Given this list of marker genes FGF23, HOXC10, HYAL2, FAM210B, CALM1, RUFY4, MECR, JPH2, STXBP4, LGALS9, INAVA, LIMA1, PRCP, CDH3, TMEM97, PNLIPRP3, ADA, ATP6V0B, MALRD1, ATP6V1G1, STAT1, SREBF2, UPK3A, ARHGEF5, AHSP, MTHFD1, FGF21, STEAP4, G6PC1, RAB11B, ACOT11, SLC12A9, CARTPT, SLC26A3, PDK2, EFNA5, CLCN6, MTLN, CCL14, CCR4, SLC22A12, MIR146A, GPRASP2, MIR15A, CCN2, SH2B2, TSHR (thyroid stimulating hormone receptor), ATP2B3, NUS1, OBP2A, TSPOAP1, CXADR, IMMT, ZNHIT1 (NCBI Gene Id 10467), VSTM4, P4HTM, BOLA2, TRPC6, PIANP, NNT, SNX10, CALCA, FOXK2, EIF4G1, STAT6, DOCK11, SLC26A4, SLC12A1, ASXL1, WHRN, CA7, SLC30A5, TTC39B, SLC26A6, RHD, MICU2, GP1BA, TSC22D4, GRAMD1B, BACE2, BCR, CXCL12, BGLAP, PLAC8, PPARGC1B, MT2A, PRDX6, SLC2A4, CCDC51, STIM2, SHANK3, ATP1B3, GP1BB, CRTC3, BCL2L11, INSR, PDE4D, CLDN12, TMPRSS6, SLC4A8, MIR204, PPP3CB, VPS54, RBM4, KCNA5, LCK, RHO, ADAM17, MT1B, CCN4, PSEN2, GNAS, RDH12, WDR48, AMBRA1, USF1, MUC6, TMCO1, IL7R, FTH1P19, COMT, SORL1, TGFB2, ATP5IF1, RACGAP1, MYO5B, NQO1, MYB, PNPLA4, PRKAB2, SLC39A10, KCTD17, PASK, CDH5, CSK, CXCR3, KIT, APOC2, SLC4A10, CRY1, MIR144, RMDN3, TRPM8, CCN3, GPR68, MB, AQP3, CRTC1, HMGB1, RHEB, CD74, FGFR4, AKT1, GNAT2, OXTR, TMEM94, ABCB4, PLCL2, MTNR1B, CD38, GRB10, DIO2, FUNDC2, AGER, FTMT (NCBI Gene Id 94033), PNLIPRP2, E2F4, CHD7, ESRRB, FGFR1, CCDC66, PRKAB1 (NCBI Gene Id 5564), ETNPPL, GAA (NCBI Gene Id 2548), CSF1, NPPC, ACACB, GATA1, CEMIP, ATP4A (ATPase H+/K+ transporting subunit alpha), GAPT, OAS1, KDM1A, RAB7A, TMEM64, CYP4F12, FOXN1, TNFRSF11A, SRF, MCOLN1, MIR185, BBIP1, TRPA1, SRI, ADAMTS5, NAPEPLD, CRH, ERCC2, STC2, RPTOR, TXNRD1, PDZD8, LAMA2, CCL5, FAM20A (FAM20A golgi associated secretory pathway pseudokinase), TMEM199, CCKBR, ATP2B2, BTK, GLRX3, GSR, CLCC1, SLC24A3, IL18R1, RMI1, PRKCE, AVPR1A, LAMTOR1, HAS2, NPR1, SMARCB1, GCM2, SLC12A8, SELENOT, LARGE2, ZNF251, NDP, TRPC3, CIB3, IKZF1, DISP3, BAIAP3, NGFR, CXCL9, SLC9A6, IGF1R, CMKLR2, SCNN1B, NMU, PRDX5, SIRT6, MPL, PLG, SPNS2, PLCB3, EPB42, MIR19B1, ANK3, SLC39A5, ADIPOR1, GSTM2, MPC2 (mitochondrial pyruvate carrier 2), ATP7A, GOT1, TNFSF13B, TXN, CMKLR1, BAP1, FKBP1A (FKBP prolyl isomerase 1A), PBLD, TWIST1, NPHP4, OSBPL11, INPP5K, UBE3A, SLC2A1, KCTD7, ATP13A4, NOVA2, HNRNPU, SLC30A9, PKN1, FXYD2, ATP13A3, PPT1, EDN1 (NCBI Gene Id 1906), PTCH1, AMPD2, ALMS1 (ALMS1 centrosome and basal body associated protein), GADD45G, NKX6-1, TMEM175, NDFIP1, CLIC2, RORA, LTBP3, SCN7A, SCO1, SEC24A, ZBED6, MED1, KLHL10, LACC1, HTR2A, ATP7B, BAK1, GDF3 (NCBI Gene Id 9573), SLC12A7, SLC45A2, PARK7, G6PC2, KRIT1, ALK, SPTA1, SLAMF8, ADISSP, CCDC47, CDH23, ISG15, PRDX2, MYC, OCLN, RAG2, CFTR, AKT3, ELP6, SLC1A1, ITPR1, ARAP1, TAL1, KCNA1, MIR320D1, EHMT1, QKI, NCAPG2, PTGS2, ACIN1, FECH, ABCB10, PROM1, NFIB, JMJD6, SLC29A1, ACSL1, SLC11A2, RNASEK, WNK1, WFS1, SLC4A3, COMMD9, DIAPH3, MT4, GATA4, GRIK2, ABCC8, TMC6, UBASH3B, IRS1, DLL1, CIAO3, AXL, SESN2, HTR4, MIR210, DMD, LDLRAP1, TPP2, NPTX1, PML, CRY2, SLC25A44, P2RX7, ACVR2A, SLC48A1, HTT, PHPT1, GCLC, ROGDI, TRPV1, CREG1, PLCE1, AGT, RP1L1, EPG5, TLCD2, SLC16A1, CNNM3, INHBA, F11R, HSP90B1, CHERP, MAPK8, SPNS1, MIR34A, BHLHA15 (basic helix-loop-helix family member a15), NELL2, CAV2, SH2B3, SSTR5 (NCBI Gene Id 6755), MUC4, CROCC, TMEM9, HCRTR1, NR5A2, CALB2, SLC24A5, USF2, ERRFI1, GPER1 (NCBI Gene Id 2852), GRM5, MIR128-1, ABCD1, DRAM2, MT1M, MFHAS1, PTPRN, TRPC5, MIR222, TRAF3IP2, TMEM14C, CALR, RAB30, FMO4, DCTN1, TMEM174, CCL7, SMAD5, PCK2 (phosphoenolpyruvate carboxykinase 2, mitochondrial), AFP, IL7, NT5E, NFE2L1, POC1B, LAMC1, MAK, YWHAE, TENT4B, SLC39A14, CASQ2, CCL11, HADH, CACNB2, PER2, MEF2C, RAP1GDS1, VGF, EGR1, IREB2, HECTD4, HCAR2, PPP2CA, CYB561A3, MERTK, PCSK1N, ATP6V1B1, WNK3, ABCG5, ACSM1, MAP2K1, COL2A1, GPR89B, SOD1, TRAF6, CYP39A1, ACADL, BBS1, KCNQ1, LRRC8E, ATP6V1A, CDH2, ZBTB20, SFTPD, CALB1, ENY2, HDAC3 (histone deacetylase 3), PDPK1, CCDC22, C19orf12, PRKCA, AQP6, SLC9A7, ANGPTL8, TRIM58, ATP6V0D1, SIDT2, HOXA5, AQP4, JAM2, FRRS1, PTH2R, UNC80, RAC1, SLC12A4, AVP, KAT7, PCTP, EPHX2, GRM2, ADCYAP1, ABCB8, RAB38, ITGB6, ADCY8, CX3CL1, ITPR3 (NCBI Gene Id 3710), KCNH2, RPE65, NF1, DRD4, CLDN18, CLN8, UBB, TRIM32, P2RX4, CCR1, ETV2, ATP1A1, COMMD1, RPS17 (NCBI Gene Id 6218), PNPLA1, EGLN2, ATP6V0D2, ATG5, PLA2G10, LIN28A, RHCG, MC4R, EDN2, ATP6V0E2, PGAM5, TRPC4, HAMP, COX19, TNFAIP3, SGCZ, ERFE, STAT3, S100A14, CADPS2, SLC39A6, SPPL2C, CUBN, XKR8, RBP1, HOXA13, MIR337, APLNR, SLC8B1, ABCB1, ATP1B1, OSBP, SLC30A10, SFRP4, SOX9, HSCB, NPC1 (NPC intracellular cholesterol transporter 1), ARMCX1, SLC4A1, GJB6, ALAS1, CRTC2, ELOVL6, SPI1, LDLR, APOM, ARSG, PERP, NCKAP1L, ADRB1, KDM6B, IL20RA, LCA5, FSHR, CHMP4B, PPP1R13L, ATOX1, PCSK9, NGF, ALPL, SLC30A7, HRC, GCGR, TLE3, EIF2AK1, CCDC186, MPIG6B, ATP6V1E1, JPH1, DHPS, CA2, SNCA, TMPRSS3, FABP5 (fatty acid binding protein 5), CAPN3, UBE2C, AKAP6, FSHB, PDX1, HKDC1, FLNA, SLC7A11, APOA2, SMAD9, TRPM7, MTM1, SLC35G1, CD40, BBLN, CLCN3, ATP2C1, ZNF423, MIR221, TMEM165, RRN3, FOXP3, ACTG1, LPL, PRDX4, VCL, HBZ, SLC17A6, TMEM119, SELENOS, ABCA3, G6PD, MIR17HG, S1PR1, GPR21, SMARCA4, PLEKHM1, IL10RA, BMP4, SLC17A7, SLC46A2, SERPINF1, APOC4, B2M (beta-2-microglobulin), CHMP2B, SLC34A3, SLC39A13, SOS1, TGM2, ABHD5, UCP2, HJV, GFRAL, TCF7L2, DRD5, SLC12A5, MIR1-1, ACVR1C, CCL23, TCEA1, PIWIL4, NR1D1, CCR2, PAX2, SCTR, MUC13, CIDEA, BBS10, LYN, OXCT1, WNT7B, CISD1, POU3F3, PLA2G12B, AP3B1, TLCD4, F2, LCAT, MT1G, RB1, HEXB, CYBA, LDB2, SPX, PTK2B, GPRC6A, EBF2, CCL3, CARD11, PTBP3, FZD9, YPEL4, HK1, SLC39A9, GP9, LDB1, IL17A, KCNK16, CLDN5, NCOA4 (NCBI Gene Id 8031), PTPRN2, CDK6, SUCNR1, BCL10, FBN1, CASQ1, BAG3, ABL1, ORMDL1, PRKACB, IGFBP5, ERN1, ADGRV1, TMEM38A, BOK, ACVR2B, PLCB4, ADGRF5, VSNL1, CES1, SNAPIN, HERPUD1, CYP4F2, ALDOA, NTSR1, NANOS1, USH2A (NCBI Gene Id 7399), MICU3, SLC8A2 (solute carrier family 8 member A2), CRB1, CYP7A1, IFT80, HMOX1, CNNM2, PRRC1, LAMA4, ATP2B4, ORMDL3, TTC7A, SYPL2, SLC25A40, ZFP36L1, LETM1, SV2B, PTPN6, NR4A3, SCRIB, ADRB2, MAP1A, PPP2R3C, UBTF, GPR137B, ILDR1 (NCBI Gene Id 449482), ABAT, VAPB, ITGB1, TBXAS1, PCDH15, TSC22D3, CLDN16, NEO1 (NCBI Gene Id 4756), BRSK2, CYP27B1, ABCG8, GSTP1, EDNRB, COL14A1 (collagen type XIV alpha 1 chain), OXT, DMXL2, BRINP1, MEX3C, PM20D1, CLN5, DNASE2, IRX3, ARNT, APOC3, MCL1, ID2, SEPTIN4, CCL21, GHRL, TJP2, CIB2, CSMD1, STK39, MED13 (NCBI Gene Id 9969), APOA5 (NCBI Gene Id 93561), ISCU, USP45, CDK16, GRINA, TSKU, BOLA3, PTPRC, SLC9A3, LEP (leptin), CYP7B1, RALY, PRKAA2, BRD1, MIF, MIR182, FUT1, MIR133A1 (NCBI Gene Id 406922), GPR15LG, ZNF675, SASH3, DYRK3, SLC4A2, BMAL1, MIR30C1, PIK3R1, C2CD2L, TXNDC2, ZFPM1 (NCBI Gene Id 161884), CDHR1, HCLS1, TXN2 (thioredoxin 2), PRKAA1, IHH, MIR33B, MT1A, WBP2NL, AFG3L2, CETP, FOXA3, PRKACA, KLF15, CCR5, NOS2, ATP6V0A2, LEPR, TRPM4, CAMK2D, ABCA12, CD19, STXBP3, ALDH1A1, ZFP36, PLCB2, POLB, FCER1G, FOXC1, CDK5RAP3, LRRC8D, GNB3, LRRC8A, PDK4, BCL6, INPP5D, ACACA, HVCN1, ANKRD54, SGCD, HCRTR2, SLC9A9, PACS2, CRACD, GCLM, KAT5, MIR590, FBXO21, MYCT1 (NCBI Gene Id 80177), APLN, UBAP2L, MIR33A, APC, BPIFA1, SMO, PIK3R2, KCNJ1, GATA3, FOXA1, SLC34A1, ACP5, APOB, ENDOG, GUCA2B, ZNF516, ASPH, NUBP1, CYP4A11, LETMD1, PTH, IL31RA, TMEM38B, SLC15A4, RTN4, MLXIPL, SMAD3, CCDC115 (NCBI Gene Id 84317), MIR320B2, CALM3, GPR82, P2RX1, NOTCH1, AIPL1, HDAC9, SENP1, FAM3D, ATP1B2, GIT1, DMTN, NXNL1, GPR27, NDN, TAOK1, TULP1, SESN3, PINK1, LIPC, AQP11, MIR320C1, CHRNA1, CLNS1A, SELENOK, ACADVL, ITPR2 (inositol 1,4,5-trisphosphate receptor type 2), RBP4, ATP6V1H, MSTN, LSR, MIR148A, ADIPOR2, SLC31A2, OR10J5, STRAP, ABCB7, TUNAR, RYR3, DEDD2, NR1H3, MAPK1, GPR89A, IGF1, SLC2A2, ANXA1, THRA, APOE, NPC2, IL2RG, RHBG, FANCE, GLS, BOLA1, TRPM5, VPS13A, ANO1, SLC25A23, WDTC1, NPY, UMOD, EPHA5, RYR2, SLC39A4, MIR320E, NKX2-3, JAK2, IFNB1, DGAT2, MICU1, SOAT2, SLC39A8, FBN2, TMEM203, HNF4A, PNPLA2, CYTL1, TF (NCBI Gene Id 7018), P2RY14, ACOT13, CYP11B1, CD24, LGR4, TRDN, KDM3A, SLC31A1, RAC3, KLF2, MAIP1, FBXO4, GIGYF2, SLC35D3, PKHD1, ZC3H8, GLRX5, F2RL3, JPH3, SIVA1, P2RY6, BOLA2B, ARID2, INHA, TNFRSF17, NUCKS1, ATP6V1G2, KL, PSEN1, NPSR1, GPR55, HTR2B, CCL2, LAMP1, CITED2, HNF1A, RPS19, DGAT1, MIR93, CLN3 (NCBI Gene Id 1201), TP53INP2, LCN6, ATP13A2, RHAG, HPX, RAB20, GPR174, WDR37, PRKN, CACNA1C, DDX3X, MAEA, NFKBIZ, PRDX3, ANKH, RAB3D, ZBTB7A, CNNM4, PRMT1, KMT2A, SLC8A3, MINAR2, TBL1XR1, FABP4, DRD2, TNF, DMPK, ATP12A, BBS2, SLC25A5, CNNM1, CORO1A, APOA1, TMOD3, SLC9B2, HEPHL1, METRNL, NOX4, FBXW7, CX3CR1, BTBD9, PNPLA3 (NCBI Gene Id 80339), TFR2, SPRR2A, NKIRAS2, SLC9C2, HSPA1A, MALL, CLSTN3, NDUFAF2, MT1H, COMP, ADCK1, PIK3CD, LOX, CCL8, FXN, CERT1, WWTR1, ABHD6, ADAR, FOXC2, ABHD4 (abhydrolase domain containing 4, N-acyl phospholipase B), MIP, TM9SF4, GCK, LPCAT1, SMAD1, RCOR1, JAK3, CCNB2, ANO6, CRB2, CTNNB1, ICAM1, ATP6V1F (NCBI Gene Id 9296), KLF13, PRDM14, SCNN1D, BSG, IL1B, ADORA1 (adenosine A1 receptor), GAS6, CHD6, LIPA, CHRNA7, NCF1 (NCBI Gene Id 653844), RRP8, MT1E, OGT, TMBIM6, RASSF2, ADRA2A, SLC1A3, HK2, ZBTB7B, MAFB, FOXA2, SLC39A7, ITGB3, SELENOW, PIK3CA (phosphatidylinositol-4,5-bisphosphate 3-kinase catalytic subunit alpha), MIR320C2, DUSP29, LIME1, MUSTN1, CDKN2A, DYNC1H1 (NCBI Gene Id 992), SCO2, PEMT, ABCG4, NEUROD1, ATP6V1G3, ABCA1, EHD1, PRLH, ASPSCR1, GCG (glucagon), IP6K1, HPS6, TGFBR3, LMO1, GPX1, FABP3, FGGY, KEL, OCIAD1, EXT2, OMA1, RFX6, SLC66A1, CXCL11, ANKRD9, DRD3, CCR7, EZH2, TGFB1, NPTN, TLCD3B, APP, VEGFA, CALCB, RPL13A, TMEM63A, ID1, FOXO1, SLC12A2, PTPRJ, TREM2, TMEM63B, SV2A, NKIRAS1, MAPK11, MTCH2, LACRT, SLC2A10, MCUB, ASCL3 (achaete-scute family bHLH transcription factor 3), CTSK, LRP5 (NCBI Gene Id 8058), SCARB1, NR1H4, HEPH, HDAC6, YBX2, PRKDC, NFE2L2, NPHP3, FAM3A (NCBI Gene Id 60343), PIH1D1, APEX1, ALOX5, ENPP7, THY1, PTPN11, TSPO, MTTP, AKR1C1, FTL, LRRK2 (NCBI Gene Id 399472), CLTRN, BECN2, SLC39A3, BAX, NPM1, DBH, ATP2A2, ARRDC3, KCNJ2, STAT5A, RHOT1, CLDN1, TMEM106B, THADA, APBB2, RP1, OSBPL8, DECR1, RAF1, DISC1, CMA1, SCARA5, NRDC, MT3, ATP13A5, ZNF830, PPARD, FADD, TSPO2, KLF1, TCIRG1, CYB5R4 (cytochrome b5 reductase 4), IL6, LYAR, MIR16-1, SH3GL2, TFE3, FLT3, NR1I2, GRID2IP, BMP6, VPS13B, APOC1, ATP6V0E1, CHMP5 (NCBI Gene Id 51612), CSF1R (NCBI Gene Id 8156), RHOT2, TFF3, ERP44, IL2RA, F2R, GCNT4, DEF8 (NCBI Gene Id 54849), CXCL6, ANGPTL4, TUB, CNTN2, AKAP11, CACNB4, NCDN, ABCA2, MIR302A, NPPB (natriuretic peptide B), RC3H1, PKD2, PTGER3 (NCBI Gene Id 5733), TRPV6, IFNG (NCBI Gene Id 3458), ORMDL2, RPS6, RPS24, RRAGA, FASLG, IRS2, MIR379, FFAR1, GLUL, RASAL2, CTSH, NR1H2, PCK1, KCNMA1, AQP1, AIM2, XCL1, CXCL10, ODAD3, INSIG1, ANK2 (NCBI Gene Id 4028), SLC46A1, TXNRD3, WNT5A, HSPA9, LGALS2, P2RY2, COX11, MAPK14, NXNL2, NEGR1, RPH3AL, STAT5B, LIPG, HAAO, ATP2B1, GPR137, SMDT1, SLC30A2, GHRHR, ERO1A, ILDR2, CCL15, ABHD8, IAPP, ACHE (acetylcholinesterase (Yt blood group)), DNAJB2, SPP1, CYP11B2, DYNLL1, MRAP2, ZFY, BBS12, SLC25A25, EDN3, CPT2, PRKACG, IL4, DRD1, FSTL1, PNLIP, ATP1A4, ADAM8, ATP6V0A1, PMAIP1, MIRLET7G, SLC12A6, FTH1, SIRT1, CPS1, PLCH2, GRN, XBP1, HK3, DIAPH1, PLCB1, SLC17A8, SLC24A2, SCT, PRLR, TNFSF14, TPT1, SLC11A1 (solute carrier family 11 member 1), SLC34A2, SOD2, YAP1, CDIN1, HSDL2, OPRK1, DBNDD2, SERPINA3 (serpin family A member 3), CACNA1S, TRA2B, SOAT1, PTGES, SCNN1A, ANGPTL3, ATP6V0A4, EXT1, EPO, GP5, PPARGC1A, MIR486-1 (microRNA 486-1), PAX6, TMC8, ABCB11 (NCBI Gene Id 8647), DMXL1 (NCBI Gene Id 1657), LDAH (lipid droplet associated hydrolase), ATP6V1D, PLCG2, SLC28A2, KMT2E, SLC4A5, PLSCR3, GPRC5B, PLCL1, TNFSF11, STIM1, KITLG, KRAS (NCBI Gene Id 3845), NOVA1, MBD5, IL1A, SOX4, GDF15, ASL, FLVCR1, CXCR4, XPR1, LNPEP, FTO, MIR320A, EMCN, PFKM (NCBI Gene Id 5215), TFRC, CCDC198, RHEX, ANG, FKBP1B, BCL2, OXSR1, CNBP, LARGE1, MIR103A1, SLC10A7, MUC17, HAP1, SAR1B, PLCG1, FIS1, SRC, COL1A1, SMAD4, SUV39H1, ANXA6, BAD, TSPAN9, TMEM18, GHITM, PIK3CB, AKR1B1, CORIN, TRIM10, KCNN4, PLA2G2A, SURF4, NADK, RAB39A, BNIP3, BBS4, ADCY6, FLCN, LRRK1, MFSD2A (NCBI Gene Id 84879), TRPV2, TRPC1, PPRC1, MC3R, UNC13B, HSPA1B, TSPAN12, NOD2, GPLD1, GLIS2, ADRB3, SLC27A1, MIR320D2, SLC25A46, ERO1B, VSIG1, SQSTM1, USH1C, SFXN1, ABCC6, POLD1, SYK, SIGLEC15, TRIM6, TJP1, ARF1, POMC, IRF4, SCNN1G, PLA2G6, ZEB2, UBE2K, SPATA7, GATA2, METTL21C, OCA2, ACOX1, CEBPB, SLC9A2, HOXB6, SLC4A11, NOS3, GRM1, PIM3, USH1G, SP3, TFF2, TNS2, CARD9, TMTC4, CD36, CLIC4, FFAR2, IL13, IDE, FOXK1, NLRP6, RAB11FIP5, PKNOX1, MYLIP, SIT1, IL18, ARMCX5-GPRASP2, TLCD1, NEMP1, IKBKG, ABCA4, MBL2, COL3A1, TASL, PDE4B, FAS, FH, CCL1, PNPLA5, MINPP1, ENPP3, MKKS, SCX, STOML2, RNF135, ATP13A1, SFXN5, GATM, PRICKLE1, CSRP3, ITPKB, NCOA5, ACTN3, SLC9A1, ABCB6, CLDN3, HIPK2, HSF1, ZNF16, ELOVL3, MAPK3, GPI, DHRS7C, KLHL3, LAMP2, ADIPOQ, ADGRG1, IQCB1, NR1D2, KLF7, SLC9A8, MT1HL1, HFE, ATP1A2, PLAA, CREBBP, EGLN1, SMAP1, CA12, STX4, TRPV4, IL15, CD2AP, ATP6AP1, MIR208A, FGF2 (NCBI Gene Id 2247), VPS33A, MCU, NHERF1, ETS1, SYBU, STK11, PHOX2B, IL20RB, SGIP1, ANGPT1, DCSTAMP, RC3H2, SLC25A38, DOCK7, IL2, MIR132, CAV1 (caveolin 1), NLE1, SLN, MLLT6, GLRX2, CNOT3, STC1, UCP1, IBTK, MKS1, JAM3, MIR27B, ATP6AP2, CCL19, BLOC1S6, SLC9A5, GBA1, CAV3, C1QTNF12 (NCBI Gene Id 388581), PTPN2, FOSL2 (FOS like 2, AP-1 transcription factor subunit), ADCY5, AQP2, CD34, GPR3, RAB11FIP2, ST6GALNAC1, SIN3A, MYH7B, XCR1, GCNT2, MCUR1, BARD1, FMO2 (flavin containing dimethylaniline monoxygenase 2), FITM2, TJP3, RCN3 (NCBI Gene Id 57333), PICALM, CEBPG, JPH4, CP, MFN2, C1QTNF4, RPS14, CYB561, ACTB, SKIL, CHST3, PRKD1, RPA1, ARMS2, CASR, AGTR1, UBA5, HEATR3 (HEAT repeat containing 3), BDKRB1, ABCA5, INS, SLC25A27, PPP1R3G, ATP6V1C1, HIF1A, PDE8B, SLC9C1, GPAM, ACO1, TLR9, PECAM1, PKP3, BMP8A, CYB561D2, SLC39A12, CEBPA, TRPM2, PRNP (prion protein (Kanno blood group)), RHCE, OTC, PRDX1, CHP1, TNNI3, PNLIPRP1, CYBRD1, LRRC19, HMGB2, SLC8A1, MTF1, CRISPLD1, GPR183, OCIAD2, PRDM16, RIPK3, LPIN1, RAG1, MT1X, TUBA1A, SLC4A7, TRPV5, DOCK10, SLC30A8 (NCBI Gene Id 169026), L3MBTL3, FTHL17, NPC1L1, LAT, MBP, PLCH1, TXNRD2 (thioredoxin reductase 2), GCKR, SLC4A9, SLC38A3, UFL1, WNT10B, SELENON, APPL2, ARID4A, ENPP1, TRIM24, LGSN, ATP5F1B, SCD, SLC4A4, CALM2, PRKCB, CNR1, NAGLU, G0S2 (NCBI Gene Id 50486), CAMLG, TM6SF2, HLA-DRB1, ATP2A3, TPP1, MUC2, ATP2C2, SLC41A1, RGN, ABCG1, CNGB1, KSR2, TMEM178A, GDF2, GJA1, KCNB1, DDIT3, TFF1, GPIHBP1, CFL2, LCN2 (lipocalin 2), P2RY1, XK, TYRO3, RBPJ (recombination signal binding protein for immunoglobulin kappa J region), PDGFC, ATP6V0C, ERCC6, EMX1, ESRRG, PACS1 (NCBI Gene Id 55690), SLC40A1, SOS2, FMO1, UBE2S (ubiquitin conjugating enzyme E2 S), ACSM2A, TLR4, RYR1, TRPC7, JAGN1, OSBPL2, PPARG, MPV17, TNFRSF13B, NOX3, EPAS1, LPCAT3, FFAR4, MT1DP, C1QTNF3, SLC9B1, NOL3, KDR, NAPSA, CYLD, KCNE3, PRND, CLRN1, COL6A1 (collagen type VI alpha 1 chain), WNK4, ATP1A3, ATP2A1, FOXO3, GSTO1, GPR12, NMUR2, TPCN2, VDR, HCRT, FCAR, ATF4, PNPLA8, NCSTN, IER3IP1, TLCD3A, MFAP2, SLC1A5, FBXL5, SLITRK1, SGCB (sarcoglycan beta), SLC24A4, SLC22A5, SLC37A4, CLN6, STEAP2, FATE1, APOA4, KCNJ10, ERC2, SLC9A4 (NCBI Gene Id 6552), SART3, IL4R, COX10, ACSM3, MAP2K6, PLN, MIR320B1 (microRNA 320b-1), SLC12A3, TESMIN, ATP4B, ADNP, IGF2BP2, EDNRA, CASP3 (NCBI Gene Id 836), BSCL2, CCL13, ZNF236, ELANE, HTR2C, WNK2, CUTC, ACVR1B, NPR3, ALAS2, RAC2, SLC30A1, PTH1R, RACK1 (receptor for activated C kinase 1), CTRC, XIAP, MT1F (NCBI Gene Id 4494), GRIN1, ESAM, DNAJA3, PYGL, TMTC2, SLC22A17, SLC24A1, BPGM, NOS1, PWWP2B, ATP6V1B2, PPP2R1A, SLC6A2, here is a description of the gene set: Human Gene Set: GOBP_HOMEOSTATIC_PROCESS species: Homo sapiens Any biological process involved in the maintenance of an internal steady state.